Given this list of marker genes NLRP2, CASP7, AIM2, CARD8, HSP90AA1, MEFV, NLRP7, CARD6, RAC1, CASP9, PRDM1, NDUFA13, NOD1, NLRP3 (NLR family pyrin domain containing 3), SUGT1, PYCARD, CHUK, RIPK2, CARD9, DUOX2, ACAP1, IL18, NAIP, XIAP, NFKBIA, NLRP1, NOD2, IKBKB, AAMP, CASP5, IL1B, CASP1, CASP8, ERBIN, NLRP10, COPS6, NLRC4, NLRP4, RELA, NLRP12, IKBKG, here is a description of the gene set: species: Homo sapiens Human Gene Set: WP_NUCLEOTIDEBINDING_OLIGOMERIZATION_DOMAIN_NOD_PATHWAY Nucleotide-binding oligomerization domain (NOD) pathway